The following is a description of a gene set: from publication Chen Y, Wang X (PMID 31504780) Genes predicted to be targets of miRBase v22 microRNA mmu_miR_96_5p in miRDB v6.0 with MirTarget v4 prediction scores > 80 (high confidence targets). studied in species Mus musculus Mouse Gene Set: MIR_96_5P, and this is the list of marker genes: Zeb1, Slc16a9, Cbfa2t3, Sox6, Atxn1, Pard3b, Tcf7l2, Zbtb37, Pdzd8, Zfp449, Bsdc1, Cdh20 (cadherin 20), Abcd1, Slc1a1, Igf2bp1, Prrx1, Abhd18, Add3, Rev1, Pde8b, Zfc3h1, Kdm6a, Tns3, Rnf139, Ccdc121rt2, Spin1, Gabrb1, Cep170b, Mitf, Inpp5a, Atxn3, Med1, Phf20l1, Ntn4, Prkce, Adgrl2, Zfp36l1, Ints8, Sort1, Vamp3, Nus1, Slc7a8 (NCBI Gene Id 50934), Gria1, Aqp5, Tmem170b, Slc12a5, Cpeb1, Dpy19l3, Chst10, Arhgap24, Uck2, Tsku, Slc39a1, Sdc2, Sinhcaf, Dcaf10, Fem1b, Tut4, Rassf8, Spen, Pmepa1, Pcdh17, Inava, Ppbp, Slf2, Adgra2, Spsb1, Hoxa9, Usf3, Cdc42bpg, Peds1, Chic1, Ostm1, Eif4ebp2, Vangl2, Gng12, Zfp345, Casp2, Slc22a5, Ehd1, Ddhd1, Ebf3, Klhl4, Arpc5l, Klhl7, Zhx2, Reps2, Brms1l, Lrrc3, Kpnb1, Gnai3, Or51ab3, Lrig1, Sh3pxd2b, Tnfrsf1b, Ttyh3, Ash1l (NCBI Gene Id 352974), Neurod4, E2f5, Fndc3b (NCBI Gene Id 99920), Phactr4, Cttn, Ccdc121rt3, Ube2g1, Wipi2, Camsap2, Phip, Rbm20, Umad1, Cnot6l, Dnaaf9, Cd164, Gcnt1, Fam43a, Stmnd1, Ube2q2, Cntn1, Stk17b, Rhpn2, Gpr22, Lmtk2, Lrrc58, Irs1, Fbxo41, Rarg, Gpc3, St6galnac3, Evi5, Zfp1005, Lrrc28, Vat1l (NCBI Gene Id 270097), Cacna2d2, Snx30, Ovol1, Nup50, Rad23b, Alk, Mfap3l, Spast (spastin), Zkscan17, Foxq1, H2-Q1, Ctdsp1, Rapgef4, Plekha7, Zfand5, Ankib1, Mtcl2, Magel2, Xkr4, Ap3s1, Morf4l1, Coro1c, Morf4l2, Lamc1, Frs2, Rasa1, Pak1, Gp1bb, Zfp961, Pcx, Anxa11, Tac1, Riox1, Hacd4, Bcl2l12, Mtss1, Fundc2, Lmtk3, Cyrib, Lgi1, St8sia3, Serpinb2, Bcr, Zic2, Cep83, Iqsec1, Bltp2, Itpr2, Prdm16, Ahr, Plekhm1, Dgkh, Tapt1, Prtg, Galnt2, Tarbp1, Ppp1r9b, Rgs2, Jazf1, Smad7, Col25a1, Map2k3, Tbl1x, Dlat, Stx5a, Gdnf, Zyg11b, Dgkk, Galr1, Slc25a1, Adam28, Myrip, Hsf5, Cep97, Retreg1, Adcy6, Foxo4, Nptx1, Nova2, Palld, Nsg1, Zcchc3, Usp5, Dock4, Itga3 (NCBI Gene Id 16400), Chrna1, Slitrk2, Arsj, Foxo1, Deptor, Ncald, Lnx2, Rab3c, Cdh7, Eif3j2, Brwd1 (bromodomain and WD repeat domain containing 1), Cacnb4, Fut9, Bnip3, Ednrb, Clock, Arf2, Sdad1, Stxbp5, Epb41l3, Ogt, Nanos1, Eif5, Zfhx4 (NCBI Gene Id 80892), Il12a, Tc2n, Oxsr1, Gfm2, Zhx1, Creb3l2, Insig2, Adgrb3, Kif19a, Zbtb41, Slain2, Brpf3, Bach2, Ddah1, Pbx2, Pappa, Gad2, Prkar1a, Yipf4, Wdr82 (NCBI Gene Id 77305), Map2k1, Zfp704, Rab8b, Grhl2, Slc6a9, Nudt13, Rictor, Slc44a2, Tmem198, Reck, Tes, Trib3, Tbr1, Dok4, Dcun1d1, Ell, Pnpla8, Epha3, Chst1, Camkk2, Has2, Fhl1 (NCBI Gene Id 14199), Tet1, Ptp4a1, Foxf2, Fign, Nexmif, Ppp4r3a, Plppr4, Tbx1, Hbegf, Abca2, Phyhipl, Rab2a, Rps6ka6, Nlgn2, Sh3bp5, Dock1, Mtor, Hook3, Yipf6, Prrt3, Gpr21, Plod2, Arpp19 (cAMP-regulated phosphoprotein 19), Ywhag, Sox5, Meox2, Gid4, Celsr1, Cnnm3, Elavl4, Ankrd27, Slco3a1, Trabd2b, Asb6, Prrg3, Bmp2k, Slc38a4, Cnn3, Celsr2, Ralgps1, Stag1, Jmjd1c, Cnot9, Grb2, Arhgef3, Taf4b, Slc18a3, Rab23, Ppp3r1, Lrch2, B3gnt2, Nptx2, Fam171a1, Unc13c (unc-13 homolog C), Celf2, Kcnj14 (potassium inwardly-rectifying channel, subfamily J, member 14), Foxk2, Slc12a6, Ezr, Olfm1, Tmem145, Lcp1, Atg9a, Tgfbr1, Gulp1, Fam168a, Hsd3b5, Snx16, Rundc3b, Dab1 (NCBI Gene Id 545665), Frmd5, Zpbp, Farp1, B4galnt1, Grk6, Sh3kbp1